Given this list of marker genes GRIK2, GRIK1, here is a description of the gene set: Kainate receptors that are formed by subunits GRIK1 and or GRIK2 that are edited at the Q/R and other editing sites in GRIK2 are Ca2+ impermeable. They permit the passage of Na+ ions. Glutamine in GRIK1 at position 636 is replaced by arginine by an editing step which occurs posttranscriptioanlly. GRIK2 is glutamine 621 is edited to arginine. GRIK2 is also edited at 571 (Y/C) where a tyrosine residue is changed to cysteine and 567 (I/V) where an isoleucine is changed to valine. All three sites are edited postranscriptionally. A fully edited GRIK2 at all three sites is impermeable to calcium ions. studied in species Homo sapiens part of: Ionotropic activity of kainate receptors Reactome Pathway: Activation of Na-permeable kainate receptors